Given this list of marker genes IGF1, SOS1, NRAS, IGF1R, GRB2, SHC1, IGF2, HRAS, KRAS, here is a description of the gene set: Reactome Pathway: SHC-related events triggered by IGF1R Phosphorylated IGF1R binds and phosphorylates SHC1. Phosphorylated SHC then binds GRB:SOS, which activates RAS-RAF-MAPK signaling. part of: IGF1R signaling cascade species: Homo sapiens